The following is a description of a gene set: Genes up-regulated more than 7-fold by expressing JAK2 in the JAK2 null cell line. species: Homo sapiens Human Gene Set: WALLACE_JAK2_TARGETS_UP from publication Wallace TA, VonDerLinden D, He K, Frank SJ, Sayeski PP (PMID 15189810) Mice lacking a functional Janus kinase 2 (JAK2) allele die embryonically, indicating the mandatory role of JAK2 in basic developmental cellular transcription. Currently, however, the downstream target genes of JAK2 are largely unknown. Here, in vitro conditions were created using a cell line lacking JAK2 expression. Microarray analysis was then used to identify genes that are differentially expressed as a result of the presence, or absence, of JAK2. The data identified 621 JAK2-dependent genes as having at least a twofold change in expression. Surprisingly, these genes did not require ligand-dependent activation of JAK2 but merely its expression in the cell. Thirty-one of these genes were found to have a greater than sevenfold change in expression levels, and a subset of these were further characterized. These genes represent a diverse cluster of ontological functions including transcription factors, signaling molecules, and cell surface receptors. The expression levels of these genes were validated by Northern blot and/or quantitative RT-PCR analysis in both the JAK2 null cells and cells expressing a JAK2-dominant negative allele. As such, this work demonstrates for the first time that, in addition to being a key mediator of ligand-activated gene transcription, JAK2 can perhaps also be viewed as a critical mediator of basal level gene expression., and this is the list of marker genes: ERG28, OBSL1, ELOA, PRPF6, SRRT, UBXN1, TMEM109, KIF22, MGST3, FAM50A, CDC25B, PPIH (peptidylprolyl isomerase H), MRPL12 (NCBI Gene Id 6182), BIN1, EPHB6, PAK1, TFDP1, POLR2J, PRSS3, CES2, H1-10, POLE, CSF3